Given this list of marker genes ATP5IF1, CALM2, TPPP3, TUBB4B, CFAP276, GSTA1, H2AZ1, CIB1, PIERCE1, TUBA1A, MORN2, ALDH3A1, H4C3, PRDX1, CETN2, DYNLT1, TUBA1B, S100A2, NQO1, CD24, SPMIP6, STMN1, CFAP144 (NCBI Gene Id 440585), CIMIP1, PTTG1, DYNLL1, TSPAN1, NTS, CIMAP3 (NCBI Gene Id 128344), MNS1, CKB, CALM1, RSPH1, PPA1, PRDX5, TUBB, CAPS, here is a description of the gene set: from publication Durante MA, Kurtenbach S, Sargi ZB, Harbour JW, Choi R, Kurtenbach S, Goss GM, Matsunami H, Goldstein BJ (PMID 32066986) Human Gene Set: DURANTE_ADULT_OLFACTORY_NEUROEPITHELIUM_UNSPECIFIED species: Homo sapiens